The following is a description of a gene set: part of: Assembly of the 9+0 primary cilium Intraflagellar transport (IFT) is a motor-based process that controls the anterograde and retrograde transport of large protein complexes, ciliary cargo and structural components along the ciliary axoneme. IFT particles contain two multiprotein IFT subcomplexes, IFT A and IFT B, with ~6 and ~15 subunits, respectively. Linear arrays of IFT A and IFT B 'trains' assemble at the ciliary base along with the active plus-end directed kinesin-2 motors and the inactive dynein motors and traffic along the microtubules at a rate of ~2 micrometers per second. At the ciliary tip, the IFT trains disassemble, releasing cargo and motors, and smaller IFT trains are subsequently reassembled for retrograde traffic driven by the now active minus-end directed dynein-2 motors. Retrograde trains travel down the length of the axoneme at a rate of ~3 micrometers per second and are disassembled and recycled for further rounds of transport at the ciliary base. Mutations in kinesin-2 motors or IFT B complex members tend to abrogate cilium formation, while mutations in dynein-2 motor or in IFT A complex members generally result in short, bulging cilia that abnormally accumulate IFT particles. These observations are consistent with a primary role for IFT B and IFT A complexes in anterograde and retrograde transport, respectively (see for instance, Huangfu et al, 2005; Follit et al, 2006; May et al, 2005; Tran et al, 2008; reviewed in Ishikawa et al, 2011). In addition to the IFT A and B complexes, the IFT particles may also contain the multi-protein BBSome complex, which displays typical IFT-like movement along the ciliary axoneme and which is required for cilium biogenesis and delivery and transport of some ciliary cargo. studied in species Homo sapiens Reactome Pathway: Intraflagellar transport, and this is the list of marker genes: TUBB3, TUBA3C, IFT70B, KIF3B, DYNC2LI1, KIFAP3, TUBA4A, DYNLT5, TUBB4A, CLUAP1, IFT80, IFT81 (NCBI Gene Id 83713), DYNC2I1, TUBA1B, IFT22 (NCBI Gene Id 64792), IFT74, IFT70A, TUBB4B, TRAF3IP1, KIF17, TUBA3D, DYNC2H1, IFT25, DYNLL1, TRIP11, DYNLRB1, IFT27, TUBB6, DYNC2I2, IFT172, WDR35, IFT57, IFT43, TTC21B, KIF3C, TUBB2B, DYNLL2, DYNLT2B, TUBB1, TNPO1, KIF3A, IFT122, TUBA1C, IFT56, WDR19, IFT140, TUBB2A, DYNLRB2, IFT88, TUBA1A, IFT20 (intraflagellar transport 20), DYNLT2, IFT46, IFT52